Given this list of marker genes KDM5D, ZFY, PRKY, RPS4Y1, EIF1AY, DDX3Y, TXLNGY, UTY (ubiquitously transcribed tetratricopeptide repeat containing, Y-linked), USP9Y, here is a description of the gene set: studied in species Homo sapiens Highly quantitative biomarkers of neurodegenerative disease remain an important need in the urgent quest for disease-modifying therapies. For Huntington's disease (HD), a genetic test is available (trait marker), but necessary state markers are still in development. In this report, we describe a large battery of transcriptomic tests explored as state biomarker candidates. In an attempt to exploit the known neuroinflammatory and transcriptional perturbations of disease, we measured relevant mRNAs in peripheral blood cells. The performance of these potential markers was weak overall, with only one mRNA, immediate early response 3 (IER3), showing a modest but significant increase of 32% in HD samples compared with controls. No statistically significant differences were found for any other mRNAs tested, including a panel of 12 RNA biomarkers identified in a previous report. The present results may nonetheless inform the future design and testing of HD biomarker strategies. Up-regulated genes detecting gender effects in global expression profiling studies. from publication Runne H, Kuhn A, Wild EJ, Pratyaksha W, Kristiansen M, Isaacs JD, Régulier E, Delorenzi M, Tabrizi SJ, Luthi-Carter R (PMID 17724341) Human Gene Set: RUNNE_GENDER_EFFECT_UP